Given this list of marker genes Gnas, Ucn, Prlh, Crh, Nmu, Adcyap1 (NCBI Gene Id 11516), Ghrh, Tac2, Tac1, Ucn2, Nppa, Tac4, Hcrt, Agrp, Apln, Cckbr, Nmb, Gnao1, Edn3, Apela, Nts, Mrap2, Pyy, Ppy, Edn1, Gal, Mrap, a, Vip, Shank1, Qrfp, Npy, Ucn3, Kiss1 (KiSS-1 metastasis-suppressor), Spx, Pmch, Pomc, Edn2, here is a description of the gene set: Mouse Gene Set: GOMF_NEUROPEPTIDE_RECEPTOR_BINDING Binding to a neuropeptide receptor. studied in species Mus musculus